Given this list of marker genes REST, NR3C1, STC2, DGKQ, CLCN2, NR5A2 (nuclear receptor subfamily 5 group A member 2), H6PD, ATP1A1, POR, ADM, HIF1A, LHCGR, DKK3, BMP5, BMP2, ARNT, BMP6, DAB2, FFAR3, EGR1, PDE8B, WNT4, here is a description of the gene set: studied in species Homo sapiens Any process that modulates the frequency, rate or extent of the chemical reactions and pathways resulting in the formation of hormones. Human Gene Set: GOBP_REGULATION_OF_HORMONE_BIOSYNTHETIC_PROCESS